Given this list of marker genes GP1BB, FGB, FGG, PRCP, F13B, F13A1, FLNA, F8, APOH, MVP, ITGB3, FBLN1, GP1BA, FGA, GP5, GP9, THBD, F12, RASAL2, KLKB1 (kallikrein B1), here is a description of the gene set: A sequential series of modifications to a set of proteins where the product of one reaction catalyzes the following reaction, ultimately leading to the generation of a mature protein. Modifications typically include proteolysis or covalent modification, and may also include binding events. studied in species Homo sapiens Human Gene Set: GOBP_PROTEIN_ACTIVATION_CASCADE